The following is a description of a gene set: Genes in the cancer module 489. studied in species Homo sapiens Human Gene Set: MODULE_489, and this is the list of marker genes: PYGM, SGCA, NCF1C, HPCA, VIPR2, CD79B, ZFY, POU6F2, NTSR1, MFNG, SLC28A1, HES2, ITGAM, NTN3, GRAP, CLCN3, PRTN3, GABRA2, ARHGAP26, KIF1A, TG, IFNA4, SOX3, ADRA1A, MAD1L1, PRM2 (protamine 2), SPTLC2, GDF5, SAG, SLURP1, REM1, GABRA3